Given this list of marker genes GLS, GLUD2, GLUD1, GLS2, GOT1, here is a description of the gene set: Human Gene Set: GOBP_GLUTAMATE_BIOSYNTHETIC_PROCESS The chemical reactions and pathways resulting in the formation of glutamate, the anion of 2-aminopentanedioic acid. studied in species Homo sapiens